The following is a description of a gene set: from publication Cui A, Huang T, Li S, Ma A, Pérez JL, Sander C, Keskin DB, Wu CJ, Fraenkel E, Hacohen N (PMID 38057668) Mouse Gene Set: CUI_NK_CELL_IFNG_RESPONSE_UP Cytokines mediate cell-cell communication in the immune system and represent important therapeutic targets. A myriad of studies have highlighted their central role in immune function, yet we lack a global view of the cellular responses of each immune cell type to each cytokine. To address this gap, the authors created the Immune Dictionary, a compendium of single-cell transcriptomic profiles of more than 17 immune cell types in response to each of 86 cytokines (>1,400 cytokine-cell type combinations) in mouse lymph nodes in vivo. A cytokine-centric view of the dictionary revealed that most cytokines induce highly cell-type-specific responses. For example, the inflammatory cytokine interleukin-1β induces distinct gene programmes in almost every cell type. A cell-type-centric view of the dictionary identified more than 66 cytokine-driven cellular polarization states across immune cell types, including previously uncharacterized states such as an interleukin-18-induced polyfunctional natural killer cell state. studied in species Mus musculus Genes positively differentially expressed in cell type: NK cell upon treatment with cytokine: IFN-γ in mouse lymph nodes in vivo., and this is the list of marker genes: Sytl3, Gnl3, Efhd2, Gspt1, Ascc3, Ndufa12, Hspa5, Nme1, Mrpl17, Tnfrsf9, Erh, Atxn2l, Rnh1, Timm50, Myo6, Atp5f1b, Nle1, Metrnl, Prmt1, Ifi27l2a (interferon, alpha-inducible protein 27 like 2A), Eif2s1, Impdh2, Ppid, Myl12a, Nop58, Gzmb, Gnl2, Ccdc124, Srsf6, Rsl1d1, Capg, Cyba, Xcl1, Sar1b, Bop1, Cycs, Farsa, Timm8a1, Rnf157, Cyld, Exosc9, Il27ra, Slc30a5, Prf1, Il12rb2, Nfkb2, Abcb1a, Lsm7, Nsun2, Tcof1, Eef1e1, Srf (NCBI Gene Id 224821), Got2, Orai1, Pa2g4, Ppa1, Ddx21, Pdcd1lg2, Cotl1, Snu13, Rpf2, Sms, Mrto4, Eif4a1, Mif, Agpat3, Hsd11b1, Eif4g1 (NCBI Gene Id 320196), Alkbh1, Ppp1r14b, Fubp1, Nfkbie, Bccip, Timm9, Cd52, Mydgf, Ncf4, Ppp1r11, Srm (NCBI Gene Id 99964), Slc7a1, Zfp706, Romo1, Gatad2a, Isg15, Ncl, Arpc2, Snrpd1, Eed, Tgfb1, Adprs, Aen, Vasp, Elp5, Eci1, Ranbp1, Pfn1, Bax, Cxcl10, Phgdh, Mepce, Slc25a5, Ddx3x, Actg1, Noc2l, Pwp1, Gpr65, Nip7, Naa20, Tusc2, Pgk1, Ppib, Cisd3, Ywhab, Ebna1bp2, Phb1, Gpatch4, Rhoc, H13 (NCBI Gene Id 99254), Npm3, Nhp2 (NCBI Gene Id 68237), Fbl, Fkbp1a, Nars1, Cmtm7, Rbm3, Uqcrq, Rrad, Gimap7 (GTPase, IMAP family member 7), Tmed5, Prmt7, Serpina3g, Tmem167, Aldoa, Uqcr11, Relb, Chrac1, Tubb4b, Tap2, Dkc1, Ube2n, Mrpl36, Ldha, Cfl1, Fasl (Fas ligand), Plcg2, Cct5, Nr2c2ap, Ube2e3, Cobll1, BC004004, Fundc2, G3bp1, Usp50, Osm, Nifk, Eif5a